Given this list of marker genes UIMC1, ABRAXAS1, COP1, KAT5, SMC3, BLM, TERF2, CDC25C, RAD17, RAD9A, ATM, RAD50, TP53BP1, BRCA1, CTBP1, MDM2, TRIM28, RBBP8, DCLRE1C, ABL1, FANCD2, TOP3A, MDC1, BID, MRE11 (MRE11 homolog, double strand break repair nuclease), YWHAB, UBE2N, CHEK2, CDC25A, XRCC4, NBN, SMC1A, H2AX, RNF8, here is a description of the gene set: Human Gene Set: PID_ATM_PATHWAY studied in species Homo sapiens ATM pathway from publication Schaefer CF, Anthony K, Krupa S, Buchoff J, Day M, Hannay T, Buetow KH (PMID 18832364)